Given this list of marker genes Ndst3, Ap2b1, Uba6, Snx15, Bend6, Abcf3, Gcdh, Khdc4, Crtc1, Tex50, Cbln4, Psd3, D130043K22Rik, Cdo1, Ccng1, Otx2 (orthodenticle homeobox 2), Actr3, Ppp3ca, Plce1, Fam135a, Zswim4, Mon2, Fam222b, Srgap2, Mosmo, Krt75, Chmp1b, Erg, P2ry14, Zcchc4, Sema6a, Ptgfr, Phactr2, Rasa1, Angpt2, Krtap4-25, Ldlrad3, Kcna4, Cstf3, Clcn5, Lnpk, Synj1, Ggt7, Rabepk, Ahcyl2, Mdfic, Nkapd1, Pan2, Fscn1, Klhl38, Myo5a, Dlgap1, Vasn, Dab2, Cpeb1, Lox, Zbtb10, Rapgef2, Casz1, Mpzl2, Adpgk, Rnf170, Spats2, Abr, Nuak1, Ivns1abp, Lrp8, Tmem178, Usp31, Dach1 (dachshund family transcription factor 1), Pcdhb18, Add3, Abracl, Lmbrd2, Macir, Cbfb, Pcsk5, Pafah1b2, Sema3a, Prr18, Pfkfb2, Srgap1, Creb5, Itln1, Eya1, Cachd1, Slc39a2, Ino80, Mrtfb, Abhd17c, Ebf3, Rc3h1, Acvr1b, Fli1, Tmem144, Pdcd1lg2, Pdcd4, Fndc3a, Zfhx4, Naa50, Tm9sf4, Dock9, Agpat3, Spsb4, Gabarapl2, Camsap2, Fnip1, Rin2, Abhd17b, Carmil1, Snx8, Rbm20, here is a description of the gene set: from publication Chen Y, Wang X (PMID 31504780) Genes predicted to be targets of miRBase v22 microRNA mmu_miR_935 in miRDB v6.0 with MirTarget v4 prediction scores > 80 (high confidence targets). Mouse Gene Set: MIR_935 species: Mus musculus